Given this list of marker genes Zbtb47, Gm26797, Gm23323, Topaz1, Ss18l2 (SS18, nBAF chromatin remodeling complex subunit like 2), Gm35549, Sacm1l, Eif1b, Gm38642, Ccdc13, Gm9856, Ccr9, Xirp1, Cyp8b1, Cxcr6, E530011L22Rik (RIKEN cDNA E530011L22 gene), 2010315B03Rik, Ano10, Gm10052, Sec22c, Gm33858, Gm5922, Lars2, Gask1a, Gm19385, Gm26448, Gm39460, Mobp, Zkscan7, Ccr2, 4632418H02Rik, Mir7090, Ccr5, Kif15, Cdcp1, Lyzl4os (NCBI Gene Id 75928), Gm39459, Tmem42, Ctnnb1, Rpsa, 5830454E08Rik, Gm39463, Entpd3 (NCBI Gene Id 215446), Ulk4, Gm17163, Snrk, Gm18101, 1700020M21Rik, Slc6a20a, Ccr8, Gm39465, Gm39456, Zdhhc3, Cck, Ccr1l1, Ccr1, Limd1, Klhl40, Lyzl4, Pomgnt2 (protein O-linked mannose beta 1,4-N-acetylglucosaminyltransferase 2), D830035M03Rik (RIKEN cDNA D830035M03 gene), Gm2774, Clec3b, 1700019L13Rik, Zfp445, Abhd5, Gm34655, Nktr, Snora62, Gm38661, 9530059O14Rik, Gm39469, Zfp660 (NCBI Gene Id 666257), Trak1, Higd1a, C230053D17Rik, Gm17021, Zfp105, Mir138-1, Vipr1, A730085K08Rik, Slc6a20b, Tgm4, Mir8106, Gm39464, 1110059G10Rik, Gm15566, Ackr2, Gm35454, Ppp2r3d, Hhatl, Gm15565, Scp2-ps2, Gm34425, Gm47112, Lztfl1, Exosc7, Nlrp4g, Tcaim, Gm47059, Gm39458, Fyco1, A530083I20Rik, Cx3cr1, Gm24044, Ccr3, Csrnp1, Gm7229, Tmem158, 4930593C16Rik, Xcr1, Myrip, Rpl14, 1700048O20Rik, Gm46136, Gm47095, Slc25a38, here is a description of the gene set: studied in species Mus musculus Mouse Gene Set: chr9F4